Given this list of marker genes APOE, HMCN1, CFH, CFI, XYLT1, MAPKAPK3, TIMP3, FBLN1, CFHR1, CLCN2, CHM, XYLT2, FBN2, FBLN5, AGXT, CLEC3B, C1QTNF5, HLA-A, EFEMP1, ENPP1, CFHR3, PRPH2, ABCC6, here is a description of the gene set: studied in species Homo sapiens Choroidal neovascularization Human Gene Set: HP_CHOROIDAL_NEOVASCULARIZATION Choroidal neovascularization (CNV) is the creation of new blood vessels in the choroid layer of the eye.